The following is a description of a gene set: species: Homo sapiens Human Gene Set: REACTOME_DEGRADATION_OF_CYSTEINE_AND_HOMOCYSTEINE Degradation of cysteine and homocysteine, and this is the list of marker genes: TXN2, CTH, SLC25A10, SUOX, MPST, GADL1, SQOR, ADO, CSAD, ETHE1, FMO1, GOT2, CDO1, TSTD1, TST